The following is a description of a gene set: Genes up-regulated in comparison of CD4- CD8- thymocytes versus CD4+ CD8+ thymocytes. Mouse thymocytes can be classified into four major subsets based on expression of CD4 and CD8 co-receptors. CD4-CD8- (double negative, DN) cells become CD4+CD8+ (double positive, DP) cells following productive T cell receptor (TCR) beta chain rearrangement. A small proportion of DP cells are selected through interaction of clonal TCRalpha/beta and MHC self peptide complex expressed on thymic stromal cells. DP cell expressing MHC class I-restricted TCR become CD4-CD8+ cells, which will finally differentiate into cytotoxic T cells, while MHC class II restricted selection generates CD4+CD8- helper lineage T cells. We used microarrays to identify genes important for thymocyte differentiation and lineage determination by profiling gene expression in different thymocyte subsets. species: Homo sapiens from publication Egawa T, Littman DR (PMID 21873191) Human Gene Set: GSE31082_DN_VS_DP_THYMOCYTE_UP, and this is the list of marker genes: NAA20, ALG3, MRPL16, FAM98B, E2F1, NBAS, TMEM106C, MGAT4B, PPIF, PRADC1, LAMTOR2, SAPCD1, MBOAT1, TSPAN4, CHCHD1, DPH5, LHPP, AFG3L2, BLMH, QTRT1, EIF4G1, GTF3C6, ST3GAL4, RPL27, RWDD4, MRPL14, MAGOH, TSN, NUDT3, LSM6, ASH2L, MRPL45, MRPL48, SIGMAR1, WDR36, PSMD6, PSMA3, EHD4 (NCBI Gene Id 30844), POLR2J, FAM185A, NTMT1, ROMO1, EIF3J, MRM1, SLIRP, ABHD11, DNAJA2, PROKR1, POLR1D, NMD3, ZDHHC3, RIBC1, SLC25A10, TOMM6, PKM, ME2 (NCBI Gene Id 4200), SVIL, IFT27, RSL24D1, OXSM, MRPS33, ECSIT, METTL5, ATG5, CHCHD6, SEC61G, NOP10, RPL18A, CIAO2A, ERI3, GET1, C15orf39 (NCBI Gene Id 56905), THRA, FAM156A, TRMT5, NUP133, STOML2, MRPS22, CEBPZOS, AP1AR, GTF2H3, CUL7, NUP93, HINT1, SOD2, PMPCA, MRPL11, LONP1 (lon peptidase 1, mitochondrial), CS, CCDC40, METTL22, ACSL1 (acyl-CoA synthetase long chain family member 1), VWCE, EPRS1, FTO, PDRG1, RIPK1, MRPL12, UQCC2, PSMD1, BMS1, NDUFB2, PARK7, KIF16B, CLN5 (NCBI Gene Id 1203), TIPIN, SLC30A7, MAGOHB, FKBP3, PDF, PTPRS, MCRIP2, CISD3, ZBTB12, EMC6, SLC25A3, MRPL23 (NCBI Gene Id 8046), YIF1B, VARS1, LDHA, GPAM, TMEM237, GOT1, EIF3A, EXOSC9, SCPEP1 (serine carboxypeptidase 1), PDCD5, WDR4, NUP107, UCK2, CRTAP, METTL9 (methyltransferase 9, His-X-His N1(pi)-histidine), GTF2E1, MRPS18A, EMC2, NUDT9, MRPL34, ADAT2, MRPL19, ATP23, BCKDK, MCM7, CARNMT1, CCT2, RAD50 (NCBI Gene Id 10111), HMGCS2, ATP5MG (ATP synthase membrane subunit g), MBTPS2, IMP4, TXNDC5 (thioredoxin domain containing 5), UTP11, HDDC2, LRRC40, TMEM205, LIG3, PRKRIP1, GPATCH1, TUBGCP2, LARS1, SERBP1, POMP, SRPK1, HACD3, TXNRD2, DHRS13, MRPS6, PPAT, DRG2, API5, SARS1, RPL23A, GSPT1, ZBTB3, HLCS, RCC1L, GRWD1 (glutamate rich WD repeat containing 1), MYDGF, PDSS2, GPI, RNF7, RSPH3, POLR1G, TOMM70, MTCH1, IQGAP2, GRPEL2, UBXN8, TMX2, DPY30, TGIF2, PSMC2, POLE3, MECR, GCN1, ATP5F1D, RPL35, COMTD1, TXNL4A, COPS2, CDK2AP2